Given this list of marker genes Eif2ak2, Ifit1, Ifi27l2a, Lgals3bp, Zbp1, Ppa1, Usp18, Ifi208, Rnf213, Ly6a, Ifi35, Ifi203, Samd9l, Oas3, Slfn5, Rtp4, H2-K1, Ifit3, Parp14, Samhd1, Ifi47, Parp9, Psmb8 (proteasome (prosome, macropain) subunit, beta type 8 (large multifunctional peptidase 7)), Helz2, Shisa5, Slfn1, Mndal, Irf7, Trim30a, Mitd1, Epsti1, Sp100, Stat1, H2-T23, Irgm1, Ms4a4b, Isg15, Bst2, Ifi206, Xaf1, Ifi213, here is a description of the gene set: from publication Cui A, Huang T, Li S, Ma A, Pérez JL, Sander C, Keskin DB, Wu CJ, Fraenkel E, Hacohen N (PMID 38057668) Mouse Gene Set: CUI_TREG_IFNE_RESPONSE_UP Genes positively differentially expressed in cell type: Treg upon treatment with cytokine: IFN-ε in mouse lymph nodes in vivo. Cytokines mediate cell-cell communication in the immune system and represent important therapeutic targets. A myriad of studies have highlighted their central role in immune function, yet we lack a global view of the cellular responses of each immune cell type to each cytokine. To address this gap, the authors created the Immune Dictionary, a compendium of single-cell transcriptomic profiles of more than 17 immune cell types in response to each of 86 cytokines (>1,400 cytokine-cell type combinations) in mouse lymph nodes in vivo. A cytokine-centric view of the dictionary revealed that most cytokines induce highly cell-type-specific responses. For example, the inflammatory cytokine interleukin-1β induces distinct gene programmes in almost every cell type. A cell-type-centric view of the dictionary identified more than 66 cytokine-driven cellular polarization states across immune cell types, including previously uncharacterized states such as an interleukin-18-induced polyfunctional natural killer cell state. studied in species Mus musculus